The following is a description of a gene set: electronically inferred by orthology from the curated human pathway Reactome Pathway: Cardiac conduction part of: Muscle contraction This event has been computationally inferred from an event that has been demonstrated in another species.<p>The inference is based on the homology mapping from PANTHER. Briefly, reactions for which all involved PhysicalEntities (in input, output and catalyst) have a mapped orthologue/paralogue (for complexes at least 75% of components must have a mapping) are inferred to the other species. species: Mus musculus, and this is the list of marker genes: Kcnk16, Trpc1, Cacng7, Casq1, Prkaca, Camk2b, Kcnip4, Kcnk5, Kcnk18, Dmpk, Cacng4, Kcne5 (NCBI Gene Id 66240), Kcnk4, Atp2b1, Stim1, Kcnj11, Cacnb1, Kcnj12, Atp1a3, Kcnk3, Nppc, Corin, Kcnk6, Atp1b3, Calm1, Tnni3, Fxyd3, Kcnk12, Npr2, Trdn, Fkbp1b, Atp2b4, Atp2a1, Atp2b3, Fxyd2, Pln, Atp1b1, Ces1d, Atp1a2, Cacna2d2, Kcnj2, Ryr1, Kcnh2, Nppa, Kcnj14, Kcnip2, Atp1b2, Atp2a3